The following is a description of a gene set: An abnormality in which the nuclei of sarcomeres take on an abnormally central localization (or in which this feature is found in an increased proportion of muscle cells). species: Homo sapiens Human Gene Set: HP_CENTRALLY_NUCLEATED_SKELETAL_MUSCLE_FIBERS Centrally nucleated skeletal muscle fibers, and this is the list of marker genes: HNRNPA1, PLIN4, MYF6, RRM1, SYNE2, SCN4A, TRIM32, MAP3K20, CACNA1S, SIL1, DNM2, CCDC78 (coiled-coil domain containing 78), JAG1, UNC45B, POLG, TWNK, MTM1, MYH7 (myosin heavy chain 7), SPEG, COL6A1, MYOT, SYNE1, MICU1, CAV3, MATR3, CAPN3, ADGRG6, BVES, POMT1, CFL2, ORAI1, MLIP, ALG2, MB, GGPS1, TTN, STIM1, TPM3, BIN1, PYROXD1, SMN1, CASQ1, HMGCR, RYR3, COL6A2 (collagen type VI alpha 2 chain), HNRNPA2B1, TOR1AIP1, OBSCN, ACTA1, TPM2, FXR1, ANXA11, TNPO3, CAVIN1, DPM3, SELENON, SMPX, RYR1, TRIP4, MTMR14